Given this list of marker genes Mt1, Muc2, Mt3, Mt2, Mt4, Atp7a, Park7, here is a description of the gene set: studied in species Mus musculus Mouse Gene Set: GOBP_DETOXIFICATION_OF_COPPER_ION Any process that reduces or removes the toxicity of copper ion. These include transport of copper away from sensitive areas and to compartments or complexes whose purpose is sequestration of copper ion.